Given this list of marker genes SERPINB13, CTSK, RUNX1, CTSL, SOCS4, CTSV, SOCS3, CBFB, here is a description of the gene set: RUNX1 regulates transcription of genes involved in differentiation of keratinocytes species: Homo sapiens Human Gene Set: REACTOME_RUNX1_REGULATES_TRANSCRIPTION_OF_GENES_INVOLVED_IN_DIFFERENTIATION_OF_KERATINOCYTES